Given this list of marker genes GADD45G, CXCL9, JCHAIN, GH1, SERPINA3, PTPRC, IGHG1, TENT5C, IL23A, here is a description of the gene set: from publication Wong YF, Cheung TH, Lo KW, Yim SF, Siu NS, Chan SC, Ho TW, Wong KW, Yu MY, Wang VW, Li C, Gardner GJ, Bonome T, Johnson WB, Smith DI, Chung TK, Birrer MJ (PMID 17043662) Endometrial cancer is the third most common gynecologic malignancy and the ninth most common malignancy for females overall in Hong Kong. Approximately 80% or more of these cancers are endometrioid endometrial adenocarcinomas. The aim of this study was to reveal genes contributing to the development of endometrioid endometrial cancer, which may impact diagnosis, prognosis and treatment of the disease. Whole-genome gene expression analysis was completed for a set of 55 microdissected sporadic endometrioid endometrial adenocarcinomas and 29 microdissected normal endometrium specimens using the Affymetrix Human U133 Plus 2.0 oligonucleotide microarray. Selected genes of interest were validated by quantitative real-time-polymerase chain reaction (qRT-PCR). Pathway analysis was performed to reveal gene interactions involved in endometrial tumorigenesis. Unsupervised hierarchical clustering displayed a distinct separation between the endometrioid adenocarcinomas and normal endometrium samples. Supervised analysis identified 117 highly differentially regulated genes (>or=4.0-fold change), which distinguished the endometrial cancer specimens from normal endometrium. Twelve novel genes including DKK4, ZIC1, KIF1A, SAA2, LOC16378, ALPP2, CCL20, CXCL5, BST2, OLFM1, KLRC1 and MBC45780 were deregulated in the endometrial cancer, and further validated in an independent set of 56 cancer and 29 normal samples using qRT-PCR. In addition, genes were differentially regulated in late-stage cancer, as compared to early-stage disease, and may be involved in tumor progression. Pathway analysis of the expression data from this tumor revealed an interconnected network consisting of 21 aberrantly regulated genes involved in angiogenesis, cell proliferation and chromosomal instability. The results of this study highlight the molecular features of endometrioid endometrial cancer and provide insight into the events underlying the development and progression of endometrioid endometrial cancer. Human Gene Set: WONG_ENDOMETRIAL_CANCER_LATE Genes down-regulated in late stage (stage 3) endometrial cancers compared to the earlier stages (stage 1 and 2). studied in species Homo sapiens